The following is a description of a gene set: part of: Telomere Maintenance Reactome Pathway: Inhibition of DNA recombination at telomere species: Mus musculus This event has been computationally inferred from an event that has been demonstrated in another species.<p>The inference is based on the homology mapping from PANTHER. Briefly, reactions for which all involved PhysicalEntities (in input, output and catalyst) have a mapped orthologue/paralogue (for complexes at least 75% of components must have a mapping) are inferred to the other species. electronically inferred by orthology from the curated human pathway, and this is the list of marker genes: H4c17, H2ac10, H2bc8, H2ac15, H4c2, H4c1, H2bc9, Terf2 (NCBI Gene Id 21750), H4c14, H4c11, H2ac11, H2ac23, H2bc22, H2bc27, H2ac4 (NCBI Gene Id 319172), H2ac20, H2az2, H2ac12, H2bc7, H2bc13, H4c3, Terf1, H4c4, H2ac1, H2ac24, H2ac19, H2bc12, H2ac22, H2ac8, Acd, H2ax, H4c9, H2bc15, H4c12, H2bc3, H3f3a, H2ac6, H2bc1, Daxx, H2ac7, H2ac13, H4c18, H4c6, H2bc11, H4c8